Given this list of marker genes ANO6, here is a description of the gene set: species: Homo sapiens part of: Defects of Coagulation cascade Reactome Pathway: Defective ANO6 does not expose PS, PE on the platelet membrane